Given this list of marker genes Il1a, Ptger2, Ptger4, Tnf, Rbbp9, here is a description of the gene set: species: Mus musculus The appearance of interleukin-33 due to biosynthesis or secretion following a cellular stimulus, resulting in an increase in its intracellular or extracellular levels. Mouse Gene Set: GOBP_INTERLEUKIN_33_PRODUCTION